Given this list of marker genes ISG15 (ISG15 ubiquitin like modifier), GBP1, OASL, IFI44L, IFIT1, IFIT3, here is a description of the gene set: Human Gene Set: CAO_BLOOD_FLUZONE_AGE_05_14YO_CORRELATED_WITH_H3N1_HI_TITER_1DY_POSITIVE species: Homo sapiens BACKGROUND: Live attenuated influenza vaccine (LAIV) and trivalent inactivated influenza vaccine (TIV) are effective for prevention of influenza virus infection in children, but the mechanisms associated with protection are not well defined. METHODS: We analyzed the differences in B-cell responses and transcriptional profiles in children aged 6 months to 14 years immunized with these 2 vaccines. RESULTS: LAIV elicited a significant increase in naive, memory, and transitional B cells on day 30 after vaccination, whereas TIV elicited an increased number of plasmablasts on day 7. Antibody titers against the 3 vaccine strains (H1N1, H3N2, and B) were significantly higher in the TIV group and correlated with number of antibody-secreting cells. Both vaccines induced overexpression of interferon (IFN)-signaling genes but with different kinetics. TIV induced expression of IFN genes on day 1 after vaccination in all age groups, and LAIV induced expression of IFN genes on day 7 after vaccination but only in children < 5 years old. IFN-related genes overexpressed in both vaccinated groups correlated with H3N2 antibody titers. CONCLUSIONS: These results suggest that LAIV and TIV induced significantly different B-cell responses in vaccinated children. Early induction of IFN appears to be important for development of antibody responses. from publication Cao RG, Suarez NM, Obermoser G, Lopez SM, Flano E, Mertz SE, Albrecht RA, García-Sastre A, Mejias A, Xu H, Qin H, Blankenship D, Palucka K, Pascual V, Ramilo O (PMID 24495909) Genes positively correlated with H3N1 HI titer in blood in children (0.5-14y) after exposure to Fluzone, time point 1D. Comment: ~80% of cohort were white, ~50/50 Female:male